The following is a description of a gene set: Human Gene Set: GOCC_ANKYRIN_1_COMPLEX A complex composed of ANK1, RHCE, RHAG, SLC4A1, EPB42, GYPA, GYPB and AQP1, that functions in the stability and shape of the erythrocyte membrane in human. species: Homo sapiens, and this is the list of marker genes: EPB42 (erythrocyte membrane protein band 4.2), AQP1, ANK1, GYPB, RHAG, GYPA, SLC4A1, RHCE